The following is a description of a gene set: Regulation of cytoskeletal remodeling and cell spreading by IPP complex components Human Gene Set: REACTOME_REGULATION_OF_CYTOSKELETAL_REMODELING_AND_CELL_SPREADING_BY_IPP_COMPLEX_COMPONENTS studied in species Homo sapiens, and this is the list of marker genes: PARVA, PARVB, ARHGEF6, ACTN1, RSU1, TESK1, PXN, LIMS1